Given this list of marker genes Rab10, Rab5a, Rac1, Rhoa, Hsp90aa1, Plxnb3, Rab3a, here is a description of the gene set: Mouse Gene Set: GOMF_GDP_DISSOCIATION_INHIBITOR_BINDING studied in species Mus musculus Binding to a GDP-dissociation inhibitor protein.